Given this list of marker genes Nrsn1, Pck1, Gm4870, Rbm14, Mt3, Rragd, Rrm2, H2ac24, Cdk1, Itgb1, Lum, Cops6, Atp1a2, Ebf1, Eif2ak2, Krt14, Ect2, Apoa4, here is a description of the gene set: studied in species Mus musculus from publication Gibbons DL, Lin W, Creighton CJ, Zheng S, Berel D, Yang Y, Raso MG, Liu DD, Wistuba II, Lozano G, Kurie JM (PMID 19404390) Mouse Gene Set: GIBBONS_GENETIC_MOUSE_MODEL_LUNG_ADENOCARCINOMA_UP_IN_METASTASIS A p53 missense mutation, R175H, found in Li-Fraumeni syndrome patients and in a subset of NSCLC patients, is a structural mutation that exhibits loss of function owing to inactivation of p53 transcriptional activity. Mutation of the corresponding arginine (R172H) in murine p53 has been previously introduced into the mouse as a knock-in allele. To evaluate the importance of p53<R172H> as a contributing event in lung tumorigenesis, p53<R172HdeltaG> mice were previously mated with Kras<LA1> mice, which develop lung adenocarcinomas owing to somatic activation of a latent Kras<G12D> allele, but rarely metastasize. Gene sets differentially expressed in the metastases of non-small cell lung adenocarcinoma tumors from Kras<LA1/+>; p53<R172HdeltaG/+> mice relative to paired primary lung tumors.